Given this list of marker genes TMED10, KIF2A, COPG1, USE1, KIFC2, KIF9, ARFGAP2, NBAS, KIF25, KLC2, TUBB6, NSF, CENPE (centromere protein E), TMED7, KIFC1, TUBA8, TUBA3D, KIF26A, RAB1B, ARF4, KIF5C, RACGAP1, ARFGAP1, KIF11, COPB1 (COPI coat complex subunit beta 1), COPA, KLC4, TUBAL3, KIF19, KIFAP3, ARF5, RINT1, BNIP1, KIF3B, KDELR2, KIF1A, KIF16B, KIF5A, TUBB3, KDELR1, KIF23 (kinesin family member 23), NAPB, KIF6, STX18, KIF4A, KIF28P, KLC1, KIF21A, NAPG, KIF15, TUBB2B, TMED9, SURF4, KIF20A, COPZ2, ARF3, KIF4B, KIF2B (NCBI Gene Id 84643), KIF2C, TUBA1A, KIF27, KIF21B, KDELR3, RAB1A, KIF20B, KIF12, TUBA4A, TMED3, KIF1C, KLC3, KIF18B, GBF1, ARFGAP3, SEC22B, TUBB4A, KIF22, TUBB1, KIF1B, ZW10, TUBA1B, TUBA3C, TUBB2A, KIF13B, TUBB8, COPE, TUBB4B, KIF5B, COPB2, KIF3A, TUBA3E, COPZ1, KIF3C, TUBB8B, KIF18A, ARCN1, ARF1, TUBA1C, TUBA4B, KIF26B, TMED2, COPG2, NAPA, here is a description of the gene set: Retrograde traffic from the cis-Golgi to the ERGIC or the ER is mediated in part by microtubule-directed COPI-coated vesicles. These assemble at the cis side of the Golgi in a GBF-dependent fashion and are tethered at the ER by the ER-specific SNAREs and by the conserved NRZ multisubunit tethering complex, known as DSL in yeast. Typical cargo of these retrograde vesicles includes 'escaped' ER chaperone proteins, which are recycled back to the ER for reuse by virtue of their interaction with the Golgi localized KDEL receptors. studied in species Homo sapiens Reactome Pathway: COPI-dependent Golgi-to-ER retrograde traffic part of: Golgi-to-ER retrograde transport